The following is a description of a gene set: Human Gene Set: HP_NUMEROUS_NEVI Numerous nevi species: Homo sapiens, and this is the list of marker genes: PTEN, CDK4, HRAS, BRAF, PCGF2, KANSL1, FGFR3, HEPACAM, PIK3CA, STK11, NRAS